The following is a description of a gene set: Human Gene Set: HP_ABNORMAL_LATERAL_VENTRICLE_MORPHOLOGY A morphological anomaly of the lateral ventricle. Abnormal lateral ventricle morphology species: Homo sapiens, and this is the list of marker genes: RNU4ATAC, PPP2R5D, MED25, NADK2, CREBBP, TAOK1, ZNF462, DCX, D2HGDH, HS6ST2, RNU4-2, TNFRSF11A, MTHFS, KAT6B, PSAT1 (phosphoserine aminotransferase 1), DOCK6, YIPF5, SNRPN, FANCI, TTC5, EML1, ATP6AP2, NAA80, PDHA1, YY1, LIPT2, ZNF148 (zinc finger protein 148), KCTD1, NCAPG2, IFT56, TAF8, KIAA0586, CLCN3, LONP1, CUX1, TUBB3, GFM2, KLHL15, COASY, KDM6A, NEK1, ADNP, TYROBP, ACP5, COG1, EBF3, DHCR7, GRIN1, DNM1, MEF2C, ASPM, GCDH, MAPKAPK5, TUBA8, HCCS (holocytochrome c synthase), VPS13A, DTYMK, STAG2, ACBD6 (NCBI Gene Id 84320), ARSI, ALDH6A1, NDUFB11, PPP1R12A, NRCAM, CLTC, ERMARD, TUBB2B, USP18, SMAD2, ALG13, MPDZ, FBXW11, COG5, NDE1, VRK1, SEC31A, PUS3, ASXL3, GRN, DHX37, SLC4A10, EIF2B5, GAN, FRA10AC1, ANKRD11, KIDINS220, KMT2D, COX7B, PEX2, NFIX, RAB3GAP1, PIGA, TMEM147, PLXNA1, SATB1, KDM1A, SPG11, PIGG (phosphatidylinositol glycan anchor biosynthesis class G (EMM blood group)), EZH2, LARGE1, AHI1, PGAP3, SRPK3, BICD2, KIAA0753, ZIC1, WARS2, VPS51, ESAM, SPRED2, AARS2, ZIC2, RNU7-1, SON, KIF26A, PEX10, HNRNPH1, ODC1, RAC1, PTPN23, CSPP1, KCNJ6, ZEB2, EP300, SMG9, ALG2, SLC35A2, GLUL, CCDC174